Given this list of marker genes PALB2, RAD51B, RAD51D, POLD4 (DNA polymerase delta 4, accessory subunit), RAD51, POLE4, RAD54B, RFC2, SEM1, POLD2, BRCA2, RPA2, POLD3, RPA1, POLH, RAD54L, POLE2, XRCC3, RFC1, PCNA, BRCA1, POLE3, RFC3, RPA3 (NCBI Gene Id 6119), XRCC2, BARD1, RFC5, RPA4, RFC4, POLK, POLD1, RAD51C, POLE, here is a description of the gene set: Human Gene Set: KEGG_MEDICUS_REFERENCE_HOMOLOGOUS_RECOMBINATION Homologous recombination. Pathway ID: N01452. Pathway type: Reference. Pathway class: nt06506 Double-strand break repair. Pathway Definition from KEGG: RPA == BRCA1+BARD1 == BRCA2+PALB2+DSS1 == RAD51 == BCDX2,CX3 -> RAD54 -> PCNA+RFC == POLD,POLE,POLK,POLH studied in species Homo sapiens